The following is a description of a gene set: studied in species Homo sapiens Aflatoxins are among the principal mycotoxins produced as secondary metabolites by the molds Aspergillus flavus and Aspergillus parasiticus that contaminate economically important food and feed crops (Wild & Turner 2002). Aflatoxin B1 (AFB1) is the most potent naturally occurring carcinogen known and is also an immunosuppressant. It is a potent hepatocarcinogenic agent in many species, and has been implicated in the etiology of human hepatocellular carcinoma. Poultry, especially turkeys, are extremely sensitive to the toxic and carcinogenic action of AFB1 present in animal feed, resulting in multi-million dollar losses to the industry. Discerning the biochemical and molecular mechanisms of this extreme sensitivity of poultry to AFB1 will help with the development of new strategies to increase aflatoxin resistance.<br><br><br>AFB1 has one major genotoxic metabolic fate, conversion to AFXBO, and several others that are less mutagenic but that can still be quite toxic. AFB1 can be oxidised to the toxic AFB1 exo 8,9 epoxide (AFXBO) product by several cytochrome P450 enzymes, especially P450 3A4 in the liver. This 8,9 epoxide can react with the N7 atom of a guanyl base of DNA to produce adducts by intercalating between DNA base pairs. The exo epoxide is unstable in solution, however, and can react spontaneously to form a diol that is no longer reactive with DNA. The diol product in turn undergoes base-catalysed rearrangement to a dialdehyde that can react with protein lysine residues. AFB1 can also be metabolised to products (AFQ1, AFM1, AFM1E) which have far less genotoxic consequences than AFB1. The main route of detoxification of AFB1 is conjugation of its reactive 8,9-epoxide form with glutathione (GSH). This reaction is carried out by trimeric glutathione transferases (GSTs), providing a chemoprotective mechanism against toxicity. Glutathione conjugates are usually excreted as mercapturic acids in urine. The main metabolic routes of aflatoxin in humans are described here. Reactome Pathway: Aflatoxin activation and detoxification part of: Biological oxidations, and this is the list of marker genes: AKR7A2, ACY3, GGT5, CYP3A4 (NCBI Gene Id 1576), GGT7, CYP1A2, GGT6, GGT3P, CYP2A13, DPEP2, MGST2, AKR7L, CYP3A5, ACY1, DPEP1, AKR7A3, MGST1, GGT1, MGST3